The following is a description of a gene set: VLDLR internalisation and degradation Mouse Gene Set: REACTOME_VLDLR_INTERNALISATION_AND_DEGRADATION species: Mus musculus, and this is the list of marker genes: Ap2m1, Rps27a, Ap2s1, Nr1h3, Cltc, Pcsk9, Ap2b1, Mylip, Uba52rt, Ap2a1, Uba52, Ubc, Clta, Ubb, Ap2a2, Nr1h2, Vldlr